The following is a description of a gene set: To develop a comprehensive catalogue of phenotypic and functional parameters of human CD4(+) T cell differentiation stages, we have performed microarray gene expression profiling on subpopulations of human thymocytes and circulating naive CD4(+) T cells, including CD3(-)CD4(+)CD8(-) intrathymic T progenitor cells, CD3(int)CD4(+)CD8(+) 'double positive' thymocytes, CD3(high)CD4(+)CD8(-) 'single positive' thymocytes, CD3(+)CD4(+)CD8(-) CD45RA(+)CD62L(+) naive T cells from cord blood and CD3(+)CD4(+)CD8(-) CD45RA(+)CD62L(+) naive T cells from adult blood. These subpopulations were sort-purified to >98% purity and their expressed RNAs were analyzed on Affymetrix Human Genome U133 arrays. Comparison of gene expression signals between these subpopulations and with early passage fetal thymic stromal cultures identify: (i) transcripts that are preferentially expressed in human CD4(+) T cell subpopulations and not in thymic stromal cells; (ii) major shifts in gene expression as progenitor T cells mature into progeny; (iii) preferential expression of transcripts at the progenitor cell stage with plausible relevance to the regulation of expansion and differentiation of these cells; and (iv) preferential expression of potential markers of recent thymic emigrants in naive-phenotype CD4(+) T cells from cord blood. Further evaluation of these findings may lead to a better definition of human thymopoiesis as well as to improved approaches to monitor and to augment the function of this important organ of T cell production. from publication Lee MS, Hanspers K, Barker CS, Korn AP, McCune JM (PMID 15210650) Human Gene Set: LEE_INTRATHYMIC_T_PROGENITOR studied in species Homo sapiens Genes enriched in the intrathymic T progenitor (ITTP) cells compared to all other T lymphocyte differentiation stages., and this is the list of marker genes: ADGRG1, CEP70, FXYD2, RRAS2, JCHAIN, CDK6, HIVEP3, ATP6AP1L, RIMS3, HOXA9, GUCY1B1, TNFSF4, MEST, TLR7, RGPD1, ETS2, GUCY1A1, GXYLT2, RAB13, NDN